The following is a description of a gene set: The chemical reactions and pathways resulting in the breakdown of insulin. Mouse Gene Set: GOBP_INSULIN_CATABOLIC_PROCESS species: Mus musculus, and this is the list of marker genes: Ceacam2, Ceacam1, Ide, Ctsd, Cela2a